The following is a description of a gene set: species: Homo sapiens KIT signaling is important in several processes including stem cell maintenance, erythropoiesis, mast cell development, lymphopoiesis, melanogenesis and maintenance of interstitial cell of Cajal. Gain-of-function mutations in KIT have been identified at low frequency in a number of diseases, including AML, melanoma and mast and germ cell tumors, and at higher frequency in gastrointesinal stromal tumors. Reactome Pathway: Signaling by KIT in disease part of: Diseases of signal transduction by growth factor receptors and second messengers, and this is the list of marker genes: STAT3, STAT5B, SRC, PIK3R3, STAT1, SOS1, KRAS, LCK, PIK3CA, LYN, GRB2, FYN, YES1, HRAS, JAK2, NRAS, PIK3R1, PIK3R2, KIT, STAT5A